Given this list of marker genes Psmc1, Psmb6, Aurkb, Cul1, Ube2d1, Psmc6, Ccna1, Rb1, Cdc26, Anapc2, Psmd6, Cdk1, Plk1, Ccnb1, Psmb7 (NCBI Gene Id 19177), Anapc10, Anapc15, Psmc3, Psmc4, Psmb4, Psma1, Ube2s (NCBI Gene Id 77891), Psmd12, Mad2l1, Psmd1, Psma7, Anapc7, Psmc5, Ube2e1, Fzr1, Psma4, Ubb, Psmb5, Cdc14a, Psmd7, Psma3 (proteasome subunit alpha 3), Rps27a, Ube2c, Psma6, Psmd13, Cdc23, Psma5, Psma2, Psmc2, here is a description of the gene set: part of: Regulation of mitotic cell cycle Reactome Pathway: APC/C-mediated degradation of cell cycle proteins species: Mus musculus electronically inferred by orthology from the curated human pathway This event has been computationally inferred from an event that has been demonstrated in another species.<p>The inference is based on the homology mapping from PANTHER. Briefly, reactions for which all involved PhysicalEntities (in input, output and catalyst) have a mapped orthologue/paralogue (for complexes at least 75% of components must have a mapping) are inferred to the other species.